The following is a description of a gene set: species: Homo sapiens Any regulation of mitochondrial membrane permeability that is involved in apoptotic process. Human Gene Set: GOBP_REGULATION_OF_MITOCHONDRIAL_MEMBRANE_PERMEABILITY_INVOLVED_IN_APOPTOTIC_PROCESS, and this is the list of marker genes: STPG1, SLC25A31, SIVA1, CAMK2A, SLC25A6, MTCH2, BOK, LRRK2, IER3 (NCBI Gene Id 91950), MIR29B1, TP53, RTL10, FZD9, SLC25A5, HSPA1A, BNIP3, PPM1K, TMEM14A, BNIP3L, ATF2, EYA2, RHOT1, BAX, MIR29A, BCL2L11, MUL1, MIR29C, TMEM102, ZNF205, BLOC1S2, BID, CHCHD10 (coiled-coil-helix-coiled-coil-helix domain containing 10), ATP5IF1, BCL2L1, GSK3B, SLC35F6, VDAC2, NOL3, HIP1R, GSK3A, MPV17L, SLC25A4, RHOT2, ACAA2, NAIF1, BAK1, GCLC, MIR17, THEM4